The following is a description of a gene set: species: Homo sapiens Human Gene Set: WP_WNT_SIGNALING_IN_KIDNEY_DISEASE Wnt signaling in kidney disease, and this is the list of marker genes: MAPK8, WNT16, WNT2B, DVL2, WNT11, FZD6, WNT10B, WNT5A, LRP6, LRP5, MAPK10, FZD4, FZD7, FZD5, FZD3, DVL1, RHOA, INVS, FZD8, FZD1, WNT4, WNT2, FZD2, WNT7B, WNT3, WNT7A, WNT1, WNT3A, WNT9B, WNT5B, MAPK9, WNT10A, CTNNB1, WNT6, DVL3, FZD9